The following is a description of a gene set: from publication Liberzon A, Birger C, Thorvaldsdóttir H, Ghandi M, Mesirov JP, Tamayo P (PMID 26771021) studied in species Homo sapiens Genes defining inflammatory response. Human Gene Set: HALLMARK_INFLAMMATORY_RESPONSE, and this is the list of marker genes: DCBLD2, CCL24, CD48, ATP2B1, GPR183, IFNAR1, TNFRSF9, CXCL8, LPAR1, CD40, MSR1, PIK3R5 (phosphoinositide-3-kinase regulatory subunit 5), HAS2, IL6, SELE, PDPN, ATP2A2, CD69, IL1R1, PVR, OPRK1, LTA, APLNR, IL1B, MXD1, PTPRE, IL18RAP, ADM, HRH1, TLR3, TAPBP, CLEC5A, CXCL6, IL4R, IL15, TLR2, IRAK2, PLAUR, ICOSLG, C5AR1, PDE4B, SLC7A2, CXCL10 (C-X-C motif chemokine ligand 10), IL18R1, KCNJ2, CCL5, KLF6, TLR1 (toll like receptor 1), BDKRB1, RGS1, P2RY2, INHBA, CD82, PTGER4, BEST1, CCL7, SCN1B, IL18, IRF7, GABBR1, CHST2, SRI, SELENOS (NCBI Gene Id 55829), FZD5, ADGRE1, PTAFR, LIF, LY6E (lymphocyte antigen 6 family member E), LYN, NPFFR2 (neuropeptide FF receptor 2), TNFSF9, IL15RA, IFNGR2, LCP2, PTGIR, RGS16, NOD2, OLR1, FPR1, SLC7A1, GNA15, GPC3, LAMP3, CCRL2, ICAM1 (NCBI Gene Id 3383), HPN, F3, CCL20, CCL17, RAF1, CX3CL1, SELL, RNF144B (ring finger protein 144B), NFKBIA, CCL2, NDP, OSMR, C3AR1 (NCBI Gene Id 719), VIP, PSEN1, P2RX7, CCL22, ITGA5, FFAR2, ABCA1, HBEGF, IL10, ABI1, ITGB8, TIMP1, RTP4, TNFRSF1B, ADRM1, KIF1B, ACVR2A, CD14, SLC31A1, CD55, SCARF1, CYBB, EMP3, CXCL9, OSM, NLRP3, IL12B, SLC4A4, CSF3R, TACR1, BTG2, MET, CDKN1A, EBI3, GPR132, TACR3, IL2RB, AQP9, GP1BA, RASGRP1, KCNA3, ATP2C1, BST2, IL7R, TNFSF10, EREG, CXCL11, NAMPT, LDLR, ADORA2B, SLC11A2, SERPINE1, RHOG, P2RX4, SLC1A2, RELA (NCBI Gene Id 5970), SLAMF1, ROS1, MEFV, PCDH7, CMKLR1, TPBG, CALCRL, TNFAIP6, NFKB1, ICAM4, SPHK1, SLC31A2, ACVR1B, LCK, MARCO, RIPK2, IFITM1, MMP14, ITGB3, IL10RA, EIF2AK2, SEMA4D, CSF1, GCH1, SGMS2, IRF1, HIF1A, STAB1, CSF3, MEP1A, CD70 (CD70 molecule), GNAI3, PTGER2 (prostaglandin E receptor 2), SLC28A2, PROK2, MYC, EDN1, KCNMB2, CXCR6 (NCBI Gene Id 10663), CCR7 (NCBI Gene Id 1236), NMUR1, NMI, AHR, AXL, TNFSF15, IL1A